Given this list of marker genes SHISA3, SOST, APP, FRMD8, DACT1, LZTS2, TLE6, WNT11, WWTR1, CTNNB1, TMEM131L, INVS, CTNNBIP1, LIMD1, CAV1, RBX1, NPHP3 (nephrocystin 3), MIR203A, CSNK1A1L, GLI1, LMBR1L, FOXO3 (NCBI Gene Id 2309), STK11 (serine/threonine kinase 11), GREM1, DAB2IP, TLE3, DRAXIN, SHISA6, SNAI2, NOTCH1, HECW1, MIR29C (microRNA 29c), RBMS3, MESP1, SMAD4, SOX2, AXIN1, LRP4, WNT5B, ANKRD6, MIR199A1, CSNK1A1, UBAC2, SFRP5, DAB2, PTPRO, SIAH2, SOX9, TLE1, MIR19B1, TLE2, MDK (NCBI Gene Id 4192), DKK4, SHH, FZD1, TMEM64, TPBG, GSK3A, DDIT3, FOXO1, CDH2, FRMD8P1, TBX18, MIR29B1, TMEM170B, IGFBP2, G3BP1 (G3BP stress granule assembly factor 1), WNT5A, MLLT3, SOX17, FERMT1, MAPK14, AXIN2 (axin 2), SOSTDC1, SOX10, HDAC1, CBY1, DACT3, CCDC88C (NCBI Gene Id 57641), SFRP4, TMEM88, NOTUM, JADE1, AMER1, SDHAF2, NKD2, RUVBL2, PRICKLE1, BMP2, KREMEN1, SOX13, CYLD, GLI3, NKX2-5, CHD8, NPPA (natriuretic peptide A), GPC3, EMD, APOE, APC, GSK3B, OTUD5 (OTU deubiquitinase 5), AMFR, TPBGL, DKKL1, DKK3, NPHP4, TLE7, MIR1-1, MIR212, NOG, STK3, NHERF1, PRKN, MCC, MIR665, TLE4, FZD6 (NCBI Gene Id 8323), TLE5, DKK2, ZNRF3, SFRP1, LATS2, CTHRC1, PPP2CA, MAD2L2, IGFBP6, DKK1, AMER2, IGFBP4, SFRP2, TMEM196, SCYL2, APC2, FRZB, STK4, PTPRU, FUZ, PFDN5, TCF7L2, ISL1, LATS1, BICC1, MIR498, EGR1, NKD1, PPP2R3A, IGFBP1, TMEM88B, here is a description of the gene set: Human Gene Set: GOBP_NEGATIVE_REGULATION_OF_CANONICAL_WNT_SIGNALING_PATHWAY species: Homo sapiens Any process that decreases the rate, frequency, or extent of the Wnt signaling pathway through beta-catenin, the series of molecular signals initiated by binding of a Wnt protein to a frizzled family receptor on the surface of the target cell, followed by propagation of the signal via beta-catenin, and ending with a change in transcription of target genes.